Given this list of marker genes DEFB104B, CDK4, MAP4K1, ADAM15, BTG2, PRKCA (protein kinase C alpha), PRKD1, FBP1, FOS, SPHK2, DEFB104A, here is a description of the gene set: Any process that results in a change in state or activity of a cell or an organism (in terms of movement, secretion, enzyme production, gene expression, etc.) as a result of a phorbol 13-acetate 12-myristate stimulus. species: Homo sapiens Human Gene Set: GOBP_RESPONSE_TO_PHORBOL_13_ACETATE_12_MYRISTATE